Given this list of marker genes Kmt5b, Pik3c2b, Klhl14, Ppm1l, Kras, Ophn1, Srsf2, Csgalnact2, Baz2a, Noa1 (NCBI Gene Id 67056), Fbxl3, Utp23, Rps6kb1, Msi2, Adamts12, Cntn4, Tmem170b, Aph1b, Wdr44, Rabgef1, Ptbp3, Prdm1, Sike1, Kcnk10, Rnf44, Insr, Uspl1, Bend3, Dtymk, 1110032F04Rik, Ythdc2, Zfp719, Nemp1 (NCBI Gene Id 72243), Fam149a, Kcnb2, Zfp606, Zeb2, Pde8b, Tiam1, Ltn1, Gpr160, Sf3b6, Rplp0, Arpc2, Snx27, Asf1a, Cadm2, Cdc42se2, Klhl31, Chsy3, Dnaaf11, Pnpt1, Mylk4, Gjd2, Rbpms, Fgfr1op2, Abl2, Magi1, Aph1c (aph1 homolog C, gamma secretase subunit), Zkscan8, Necab1, Cep97, Gprasp1, Sypl2, Crppa, Yaf2, Mbnl3, Plagl1 (pleiomorphic adenoma gene-like 1), Zfp459, Mapk8, Cnot6l, Dcun1d4, Tmem33, Rabif, Fbn2, Fam135b, Pptc7, Zfp760, Pkdrej, Otol1, Dimt1, Arl13b, Slain1, Kcnj8, Bahd1, Krit1, Scaper, Bcl10, Ppp2r1b, Slc35e1, Cep15, Aff4 (AF4/FMR2 family, member 4), Gnb4, Rab38, C9orf72, Ssbp2, Irx1, Svbp, 1700066M21Rik, Capza2, Rere, Armcx4, Fbxl17, Coa3, Cfl2, Nol10, Pcmtd1, Stxbp5, Mxi1, Npas3, Cln5, Txlnb, Zfp941, Olr1, Zfp971, Tpbg, Nbeal1, Cpeb4, Cstf2, Ss18, Rigi, Ppm1a, Kif2a, Ly6m, Col1a1 (collagen, type I, alpha 1), Cd2ap, Lamp3, Nim1k (NCBI Gene Id 245269), Paip2, Fmn2, Gadl1, Cdk12, Rpl5, Sclt1, Sipa1l2, Polr3gl, Akap11, Mgat4a, Sema4c, Hes1, Dek, Clock, here is a description of the gene set: species: Mus musculus Mouse Gene Set: MIR_295_5P from publication Chen Y, Wang X (PMID 31504780) Genes predicted to be targets of miRBase v22 microRNA mmu_miR_295_5p in miRDB v6.0 with MirTarget v4 prediction scores > 80 (high confidence targets).